Given this list of marker genes ABL2, CLASP2, ABL1, ROBO1, SLIT2, CLASP1, CAP1, CAP2, here is a description of the gene set: ABL (ABL1 or ABL2) plays a dual role in the ROBO pathway. As a key enzymatic component in the signaling pathway, ABL supports repellent signaling (by recruiting the necessary actin binding proteins) and also feeds back on the receptor (by down regulating through phosphorylation) to adjust the sensitivity of the pathway.<br>ABL cooperates with multiple effectors, including the actin binding protein Capulet (Capt) and Orbit/MAST/CLASP, suggesting that ABL simultaneously coordinates the dynamics of two major cytoskeletal systems to achieve growth cone repellent guidance. studied in species Homo sapiens part of: Signaling by ROBO receptors Reactome Pathway: Role of ABL in ROBO-SLIT signaling